Given this list of marker genes CACNB3, SLC4A2, HSPB1, CSK, PLXNB2, S100A8, ASGR2, C2, S100A9, STAR, TRANK1, SERPING1, HDAC5, PPP2R5D, NDUFS2, MARCKSL1, SRPK2, DHCR7, ADAM8, GGH, NAA80, CPB1, SGK1, TNFSF14, GRB2, SMG5, YARS1, HSD11B1, IDO1, CHI3L1, NUP93, CYP1A1, ZNF473, CTSO, IFI27 (NCBI Gene Id 3429), IL2RG, GPX4, HLA-DQA1, CEBPA, SLC25A1, GALK2, ENC1, DOK1, FGL2, PTK2B, SLF2, IER2, PSMB9, NDRG1, CKS2, RRP8, RALY, TMEM151B, LGALS3BP, DNAJB5, FZD2, FLOT2, CSNK1G2, PLCG2, ECHS1 (NCBI Gene Id 1892), GAS2L1, PSMB1, JUND, TAPBP, POLR2A, BLOC1S1, CCL22, IL13, RGS2, HLA-DQB1, PSMD5, AARS1, FYB1, FAM53B, VOPP1, PXDN, EFHD1, FADS2, CD52, LILRA3, PRKAR2B, IL1R2, MASP1, ITGB2, NRDC, TAF5, POLR2H, FADS1, SERPINF1, PLIN3, WARS1, PRKD2, TMEM184B, MEA1, STX8, SLC7A7, FIBP, NRGN, PLAAT4, PSME2, SCGB1A1, MNT, COX7A2, CIC, HCAR3 (NCBI Gene Id 91492), KIAA0513, TMEM147, PDGFB, PSMB10, KLK6, YWHAH, RHBDD3, RRBP1, FCGR3A (NCBI Gene Id 2214), ARF3 (ADP ribosylation factor 3), TGFBR2, FCN1, HMGN1, SMAD6, CRIP1, BTN3A3, HLA-DRB4, HCP5, SMCP, PPM1F, HBEGF (heparin binding EGF like growth factor), EGR3, TYMP, FIG4, SPN, CDKN1A, PEA15, WRN, LTA4H, CDC25B, JMJD6, NDUFAB1, LST1, ITGAL, INPP5K, SDC3, CROT, SERPINA1, HES1, ITPA, ANOS1, MYCBP, LMAN2, DDB2, FCGR1A, ALDH3B1, FGR, SIRPB1, NBEAL2, NPAT, STK38L, CLK3, ASNS, HLA-F, DHCR24, WDR7, PNPLA6, SGCG, FBP1, BST1, JUNB, UBB, VAMP5, ATPAF2, PHKG2, CD55, TBCE, NPM3, DUSP1, TXNIP, INPP5D, SDHA, HTT, TADA3, MEF2D, POLR2G, NDUFS3, ASH2L, PSMB6, MARS1, PPP1R7, ACAT2, NBAS, ATP5PO (ATP synthase peripheral stalk subunit OSCP), CAMK1, DAG1, NDUFA1, NDUFV2, NCLN, CCR2, PTPN6, EBP, GBP2 (guanylate binding protein 2), TAF10, here is a description of the gene set: from publication Wu HJ, Ivanov II, Darce J, Hattori K, Shima T, Umesaki Y, Littman DR, Benoist C, Mathis D (PMID 20620945) studied in species Homo sapiens Human Gene Set: GSE22140_HEALTHY_VS_ARTHRITIC_MOUSE_CD4_TCELL_UP A general defect of GF K/BxN T cell proliferation response toward antigen motivated us to look for the impairment in GF K/BxN T cells that might leads to the low Ab production and reduced disease phenotype seen in GF K/BxN mice. To find the difference between GF and SPF K/BxN T cells in a broad and non-biased fashion, we performed gene-expression profiling of these cells using microarrays. Genes up-regulated in CD4 T cells under specific pathogen free conditions: healthy versus arthritis (KRN model).